The following is a description of a gene set: Mouse Gene Set: GOCC_CHROMOSOME_CENTROMERIC_REGION species: Mus musculus The region of a chromosome that includes the centromeric DNA and associated proteins. In monocentric chromosomes, this region corresponds to a single area of the chromosome, whereas in holocentric chromosomes, it is evenly distributed along the chromosome., and this is the list of marker genes: Smarcd1, Arhgap33os, Cenpc1, Smc1a, Septin2, Nde1, Macroh2a1, Sgo2a, Kdm4b, Cenps, Ttk, Sin3a, Wdhd1, Nek2, Ppp2r5c, H4c2, Dapk3, Rad21, Firrm (NCBI Gene Id 381306), Smc4, Xpo1, Ppp1cc, Uhrf2, Cenpi, Mad2l1, Nudcd2, Ckap5, Pole3, Cfdp1, Kat8, Ezh2, Mis12, Dctn6, Nup85, H4c11, Kat2b, Nup133, Hnrnpu, Cdca8, Dnmt1, Smarce1, Cenph, Smc3, Ppp1r12a, Cdc20, Sugt1, Cenpm (centromere protein M), Chmp1b2, Cenpl, Dsn1, Septin6, Zfp618, Cenpp, Sirt6, Pmf1, Dynll1, Chmp4c, Kdm4a, Ska1, Phf10, Dync1li2, H4c9, Mtbp, Ss18l1, Lrwd1, Kdm4c, Ccnb1, Aurkb, Kmt5b, Stag2 (NCBI Gene Id 78442), H2ac23, Hsf1, Zfp276, Chmp2a, Smc1b, Smarcc2 (NCBI Gene Id 68094), Atrx, Zfp330, Cenpv, Kif2c, Phf2, Incenp, H4c3, Chmp5, Kansl1, Psen2, Sycp2l, Septin7 (NCBI Gene Id 235072), Smarcc1, Sycp3, Pkhd1, Baz1a, Phf6 (PHD finger protein 6), Champ1, Arid2 (AT-rich interaction domain 2), Ercc6l, H2ac22, Sgo2b, Tpr, Chmp6, Kif18a, Suv39h2, Bub1b, Dync1i1, H2ac8, Prpf4b, Nup37, Esco2, Luzp1, Mki67, Meikin, Kntc1, Ppp2cb, Zwilch, Fbxo28, H2ac13, Pafah1b1, Cenpk, Cenpn, Spdl1, Bub3, H2ac6, Rangap1, Smarcd2, Kat7, Cenpe, H4c16, H2ac4, H2ac7, H4c6, Bub1, Spout1, Dynlt3, H4c4, Cenpa, Nuf2, Dctn3, Mtcl1, Actl6a, Stag3, Gtf2b (NCBI Gene Id 229906), Knstrn, H2al2a, Ikzf1, Clasp2, Dctn4, Tex14, Kmt5c, Ndc80, Ngdn (NCBI Gene Id 68966), H3f3a, H4c8, H4c14, H4c18, Bod1, Chmp7, Plk5, BC005624, Smarca5, Ppp2r1a, Ncapd3, Nup98, Fbxw11, Gpatch11, Chmp3, Ska2, Apc, Ncapg, H4c12 (NCBI Gene Id 319160), H4c17, Zfp207, Itgb3bp, Zwint, Ctcf, Hells, Rcc2, Ahctf1, Knl1, Mad1l1, Kat5, H2bc21, Plk2, H2al1a, Cbx3, Dnmt3a (DNA methyltransferase 3A), Sycp1, Cbx1, Cenpw, Smarcb1, Spag5, Dnmt3b, Ppp2ca, Chmp2b, Chrac1, Cdt1, Pinx1, Oip5, Trp53bp1 (transformation related protein 53 binding protein 1), Aurka, Hjurp, Pbrm1, Nup43, Zw10, Rassf2, Dctn2, Kif2b, Mis18a, Smc5, Actl6b (NCBI Gene Id 83766), Snai1, Suv39h1, Birc5, Dscc1, H2ac24, Cbx5, Cenpt, Cenpx, Psen1, Chmp1a, Sycp2, Cenpu, Flywch1, Ska3, Orc2, Kdm4d, Uvrag, Spc25, H4c1, Nup107, Fmr1, Actb, Anapc16, Cenpf, Chmp4b, Rec8, Trappc12, Crebbp, Dctn1, Clasp1, Smarca4, Dync1li1, Cenpo (NCBI Gene Id 76550), Cenpb, Top2a, Cenpq, Aurkc, Dctn5, Spc24, Nsl1 (NSL1, MIS12 kinetochore complex component), Sgo1, Baz1b, Chmp1b, Csnk1a1, Plk1 (NCBI Gene Id 18817), Nup160, Brd7, Plk3, Ppp2r5a, Ndel1, Smc6, Meaf6, Sec13, Ncapd2, Mis18bp1, Cebpb (CCAAT/enhancer binding protein beta), Nsmce1, Ccnb1-ps, Seh1l, Daxx